Given this list of marker genes AMMECR1, ABCC8, H3C6, AQP7, TSSK2, EPHB2, SLC4A8, ABCB10, ZNF33B, ABCB1, MYL3 (myosin light chain 3), IGKV7-3, LGI1, FPR2, ZP2, HSD3B2, IL11RA, FOSL1, CYP2C19, NTNG2, COLGALT2, KDR, RXRG, CDC73, ZNF133, ARL3, SGCD, PKP1, TANC2, SIM2, MAGEC1, BMP10, OPLAH, HTR3A, PGM3, AOC4P, SERPINA4, NPFF, CYP2D6, SCN7A, FGF18, NFAT5, NRXN1, KRT2, HOXD13, PTPRB, SLC26A4, WBP4, GJB5, MEOX2, ERC1, FBXL4, TBX19, COL19A1, TMEM26, ERCC4, ITIH3, SLC22A6, RREB1, ELAVL2, NR1I2, LORICRIN, SPA17, ZBTB40 (NCBI Gene Id 9923), S100A5, PDE4D, RUNX2, COX6A2, JRKL, ZSCAN26, here is a description of the gene set: Neighborhood of MYL3 myosin, light chain 3, alkali; ventricular, skeletal, slow in the MORF expression compendium species: Homo sapiens Human Gene Set: MORF_MYL3 Neighborhood of MYL3